Given this list of marker genes Angpt2, Serpini1, F2, Lgals4, Col4a5, Ctsa, Prl3d1 (NCBI Gene Id 18775), Muc5b, Ccl12, Serpinb9c, Serpina10, Adam8, Pgf, Sema3d, Tinag (NCBI Gene Id 26944), Zp1, Fgf7, Sdc1, Adamtsl3, Stfa1, Ccl4, Sbspon, Tnfsf4, Egfl6, S100a1, Wnt9b, Clec12a, Ambn, Serpinb9b, Prl8a1, Ovgp1, Fgl2, Masp1, Fgf23, C1qa, Muc17, Cst11, Creld2, Ngf, Hpse2, Lman1l, Loxl1, Ism1, Cdcp2, Clec2l, Il36b, Fgb, Muc1, Gdf7, Serpina1a (serine (or cysteine) peptidase inhibitor, clade A, member 1A), Fgf4, Clec3a, Nell2, Tnfsf18, Ntn3, Sdc2, Serping1, Ncan, Cst8, Serpinb3b, Gm13285, Clec4b2, Col3a1, Ifna15 (NCBI Gene Id 242517), Fgf20, Serpinb5, Col6a4, Igfbp7, Reg3a, Adamts12, Fgf2, S100a11, Fbn1, S100b, Pdgfd, Lama5, Fgf11, Adam1a, Spock2, Pdgfb, Angpt4, Col13a1, Col17a1, Il1rn, Thbs2, Adam12, Col4a1, Adam6b, Ccl3, Acan, Cbln3, Elfn2, Prss3l, Serpinb9, Pik3ip1, Cst3, Col6a6, Ccl1, Cxcl12, Hyal3, Npnt, Wnt8b, Gdf11, Fndc7, Col23a1, Fndc1, Adam33, Comp, Adam32, Lgi1, AW551984, Astl, Lgals3 (NCBI Gene Id 16854), Cxcl15, Pcsk5, Gdf15, Ifna9, Mmp23, Il18, Fstl3, Pxdn, Lgals1 (NCBI Gene Id 16852), C1qtnf12, Fn1, Adam23, Fgf10, Tnfsfm13, S100z, Nrg4, Serpinb2, Anxa9, Clec5a, Adamtsl5, Gpc1, Sftpc, Tnn, Bmp8b, Lama3, Pappa, Impg1, Serpinb6d, Egln3, Gdf10, Sema6a, C1qtnf1, Agrn (NCBI Gene Id 381587), Serpina3c, Il36rn, Reg2, Ifng, Bglap3, Serpinb9f, Chad, Adamts6, Masp2, Tnfsf9, Lefty2, Prl2b1, Sema5a, Wnt11, Serpinb6c (NCBI Gene Id 97849), Vwa3a, Csta2, Serpina6, Shh, Ints6l (NCBI Gene Id 75165), Lta, Csf3, S100a7a, Serpinb12, Adam1b, Mmp14, Nid1, Fam20c, Fgf22, Fgf21, Cxcl10, Serpinb7, Bmper, Fgf12, Col9a3, Lum, Serpinb9e, Fgf6, F7, Adam30, Gdf1, Il2, Vwce, Ifna12, C1qtnf3, Epo, Nell1, Nyx, Adamts3, Emcn, Plau, Pamr1, Muc15, Mfap5 (microfibrillar associated protein 5), Mfap1b, Gm5849, Ctsk, Serpina1d, Papln, Col5a3, S100g, Cripto, Ogn, Col5a2, Il7, Plxnb2, Timp3, Clec12b, Prl7d1, Egfem1, Ibsp, Gdf6, Vwde, Wnt2b, Mfap3, Ccl8, Prss12, Anxa11, Mmrn1, Tgm1, Fcnb, Prl8a2, Lgals7, Megf11, Cts3, Slit2, Sema3f, Col8a2, Hrnr, 1810010H24Rik, Mmp9, Cpn2, P4htm, Thpo, Clec4d, S100a2, Fmod, Mmp10, Tnfsf12, Mepe, Emilin3, Emid1, Fgf17, Cd209a, S100a4, Adamts20, Chrd, Sparcl1, Cxcl9, Egfl8, Adam18, Adamts2, Ccn6, Cspg4, Artn, Tll1, Tnfsf11, Hmcn1, Sema6d, Mmp17, Il17c, Serpina7, Plat (plasminogen activator, tissue), Ccn2, Egf, Cfc1, Prl2a1, Fgfbp1, Sema5b, Bmp4, P4ha3, Pappa2, Stfa2, F12, Itih1, Clec2i, Mmp7, Timp4, Lgals9, Wnt3, Cxcl2, Mfap2, Gdnf, Rspo3, Il36a, Col9a2, Itih5, Cxcl1, Dmbt1 (deleted in malignant brain tumors 1), Prl8a8, Il11, Angptl2, BC051665, Ccl20, Dmp1, Tnfsf10, Htra1, Csf1, Agt, Cd209d, Cilp2, Fgf8, Mmp20, Reln, Cela3a, Mfap4, Serpine3, Ccl24, Adam19, Il10, Adam4, Lrg1, Ntn4, Ctsf, Sema4c, Serpina1b, Gpc4, Slpi, Mmp27, Wnt5a, Serpinb11, Plg, Prss1 (NCBI Gene Id 22071), Serpina1e, Prl8a6, S100a9, Spon1, Fbln5, Megf6, Lamc1, Fgf5, Prl7a1, Itln1, Col20a1, Gldn, Prl7c1, Lman1 (NCBI Gene Id 70361), Serpina3k, Serpina5, Ints14, Colec10, Il12b, Igfbp4, Fgf18, Lgals12, Clec4a2, Mep1a, Plxna4, Clec3b, Il16, Sema4f, Nrg2, Ccl27a, Ccn4, Col6a1 (collagen, type VI, alpha 1), Ifna1, Angptl1, Rspo2, Ihh, S100a16, Col25a1, Ccl7, Gpc2, Clec2j, Il4, C1qtnf2, Rspo1, Ctf2, Hapln1, Parm1, Vwc2l, Sftpd, Serpinb1a, Tgfb3, Vwa7 (NCBI Gene Id 27762), Serpinb13, Sema6c, Colq, Clec2e, Lama4, Plxna1, Bsph1, Epgn, Bmp1, Ifna4, Kcp, Lama2, Sema7a, Ctsd, Muc21, Adamts8 (ADAM metallopeptidase with thrombospondin type 1 motif 8), Bmp7, Col12a1, Sema4g, Eda, Cd109, Ecm1, S100a3, Igfbp2 (insulin-like growth factor binding protein 2), Reg1, Ctsl, Col6a5, Try5, Srgn, Gdf2, Tnfsf14, Igsf10, Xcl1, Mbl2, Zpld1, Il23a, Rptn, Adamts16, Igfbp3, Igfbpl1 (NCBI Gene Id 75426), Adamts10, Oit3, Tecta, Ifna13, Angptl4, Fbln1, Fbln7, Ctsq, Ifna2, Anxa4 (annexin A4), Cilp, Cts7, Cstdc3, Col4a2, Prss1l, Ccn5, Gm13283, Timp1, Pdgfa, Fstl1, Spock3, Matn3, Crnn, Prl3d2, Inha, Abi3bp, AI182371, Lamc2, Il1b, Thbs4, Nrg3, Mmp1a, Adamts5, Hyal4, Wnt7b, Loxl3, Prl2c2, Gm4787, Flg, Spon2, Col18a1, Nid2, Il17d, Slit3, Sema6b, Serpinb9d, Lamb1, Adipoq, Ctsc, Ifnb1, Wif1, Adam2, Tgm2, Stfa3, Plod2, Edil3, P4ha1, Fgf15, Tnf, Serpina11, Wnt10a, Hspg2, Rspo4, Gm13277, S100a8, Gm13288, Ccl19, Gpc5, Mmp8, Ebi3 (Epstein-Barr virus induced gene 3), Tnc, Crim1, Mdk, Otog, Mug2, Reg3d, Pcsk6, Ctsg, Vit, Podn, Adamtsl4, Ctsz, Ecm2, Col1a1, Lgi4, C1qtnf9, Wnt3a, Zp3r, Il15, Wnt4, Crispld1, F13b, Prg3, Hyal5, Fbln2, Serpina3a, Muc6, Serpina3g, Tnfsf13, Muc19, Lefty1, P4ha2, Sfrp1, Ppbp, Col2a1, S100a6, Gm5409, Tsku, Ccbe1 (NCBI Gene Id 71072), Insl5, Lgi2, Ccl26, C1qtnf5, Gdf5, Vwc2, Tgfa, Adam26a, Ptn (pleiotrophin), Fgl1, Adam5, Ltbp3, Clec10a, Hpse, Tchh, Il1a, Fga, Anxa10, Plxna2, C1ql2, Cst6 (NCBI Gene Id 98169), Inhbb, Cbln2, Mmp13, Wnt1, Slamf6, Zpld2, Col6a2, Bsph2, Clec4e, Il20 (NCBI Gene Id 58181), Podnl1, Igf1 (insulin-like growth factor 1), Brinp2, Lep, Cx3cl1, Clec2h, Clec1a, Mmp19, Igf2, Fgf9, Wnt2, Col11a2, Sned1, Sema4b, C1ql4, Col7a1 (NCBI Gene Id 12836), Itih4, Srpx, Gm13271, Prl3c1, Serpinc1, Gdf3, Pspn, Adam26b, Zp3, Kera, Cd209b, Fras1, P3h1, Itih3, Prl8a9, Col27a1, Crhbp, Lamb2, Adam21, Reg4, Sfrp2, Lif, Igfbp1, Col26a1, Sdc3, Serpine2 (serine (or cysteine) peptidase inhibitor, clade E, member 2), Bmp2, Serpina3f, Col19a1, Adam7, Pzp, Csf2, Bmp8a, Prl, Colec12, Wnt7a, Tmprss15, Sdc4, Ccl6, Mstn (NCBI Gene Id 17700), Vegfa, Sparc, Kazald1, Chrdl2, Ntn5, Il17b, Plod3, Hyal6, Ctsw, Ntn1, Colec11, Megf9, Tgm3, Hhip, Vwa5a, Sema3g (NCBI Gene Id 218877), Ctf1, Vegfd, Nrg1, Sema3a, Gm13287, Bmp6, Vtn, Adamtsl2, Sema3b, Anxa8, Il1f10, Clec2d, Sfrp4, Serpinb1b, Ambp, Grem1, Scube3, Serpinb8, Ndnf, Ccl9, Crlf1, Prol1, Ogfod1, Ctse, Clec4g, Matn2, Wnt10b (wingless-type MMTV integration site family, member 10B), Lamb3, Cela1, Adamts13, Mep1b (NCBI Gene Id 17288), Clec7a, Adamts19, Fgf14, Il5, Clec4a4, Pdgfc, Mfap1a, Anxa13, Adamts1, Clec4b1, Ntf3, Serpinb10, Amelx, Pf4, Cxcl13, Pcolce2, Lgals8 (lectin, galactose binding, soluble 8), Vwa2, Lox, Frem2, Adam25 (ADAM metallopeptidase domain 25), Gdf9, Emilin2, Cntf, Itih2, Sfta2 (NCBI Gene Id 433102), Clec14a, Col6a3, Bmp10, Il17a (interleukin 17A), Adam6a (a disintegrin and metallopeptidase domain 6A), Mmp12, Col4a6, Loxl2, Ifna16, Prl7a2, Slit1, Srpx2, Prss3, Ins1, Muc20, A2ml1, Spock1, Amh, Mucl1, Pcolce, Ccl11, Vwf, Col22a1, Hapln2, Serpinb6b, Ctso, Vwa5b1, Ltbp1, Ntng1, Plod1, Prl2c5, Hmcn2, Cdcp3, Wfikkn1, Cbln4, Il17f, Megf8, Sema4d, Matn1, Cbln1, F9, Igfals, Dpt, Aebp1, Htra4, Ccl21a, Serpinb3d, Ifnab, Htra3, Bmp3, Prl2c3, Scube2, Hpx, Megf10 (NCBI Gene Id 70417), Col10a1, Fndc8, Reg3g, Lgals2, Mst1, Kng2, Cst7, Serpinb3a, C1ql1, Try4, Col15a1, Serpinb3c, Cstl1, Anxa2, Tnfsf8, Bmp5, Inhba, Prss2, Cela2a, Adamts4, Ins2, Adam11, Clec9a, Serpinh1, Serpina3b (NCBI Gene Id 271047), S100a5, C1ql3, Egflam, Angpt1, Ccl22, Ky, Gas6, Nodal, Ntng2, Dspp, Muc2, Col24a1, Adam29, Gm5347, Smoc2, Mmp3, Clec11a, Tchhl1, Clec4a3, Vcan, P3h2, Lgalsl, Tgm5, S100a14, Ifna5, Angptl3, Tnfsf15, Eln, Cts8, Insl6, Clec4a1, Adamtsl1, C1qtnf4, Epyc, F13a1, Sulf1, Sema4a, Fgf3, Cstdc1, Wnt9a, Ereg, Vegfc, Esm1, A2m, Mgp, Serpina12, Tgm4, Angptl7, Crispld2, Kitl, Sema3e, Cst13 (NCBI Gene Id 69294), Prl2c1, S100a10, Adam15, Sfrp5, Clec4f, Ctsj, Cxcl11, Col5a1, Ifna6, Ccn1, Serpina1f, Clec4n, Cstb, Grifin, Cts6, Ifne, Vwa3b, Il22, Gm13276, Tectb, Cstdc2, Serpinf2, Muc4, Mmp16, Ctsll3, Cela3b, Mbl1, Gpc6, Spinkl, Adam22, Adam3, Cst5, Fam20b, Clec18a, Il3, Adam20, Fam20a, Omd, Sulf2, Creld1, F10, Col14a1, Il9, Bcan, Il24, Adam9, Tinagl1, Plxna3, Gm13278, Mmrn2, Hyal2, Reg3b, Hapln4, Prl4a1, Cxcl14, Mmp11, Ifna7, Timp2, Dhh (desert hedgehog), Stfa2l1, S100a13, Thsd4, Gh, Fgf13, Ltbp2, Ctss, Wnt8a, Elane, Ctsm, Vegfb, Serpina9, Gm13289, Insl3, Hyal1, Wnt5b, Efemp2, Adam39, Fst, Bgn, Kng1, Sema3c, Prl3b1, Ctsb, Col11a1, Ifnz, Chadl, Anxa6, Egln2, Ifna11, Frem1, Sftpa1, Tpbpa, Cst9, Ltb, C1qb, Tgfb1, Efemp1, Zp2, Anxa7, Chrdl1, Thbs1, Prl5a1, Osm, Tnxb, Smoc1, Tnr, Serpina3m, Serpinb9g, Egln1, Fbn2, Btc, Adam24, Il36g, Emilin1 (NCBI Gene Id 78939), Ifnk, Mmp21 (matrix metallopeptidase 21), Nrtn, Otol1, Fasl, Crlf3, Tnfaip6, Cspg5, Prg4, Mmp24, Tgfb2, Sftpb, Adamts14 (NCBI Gene Id 631313), Prg2, Fgfbp3, Plxdc1, Il25, Flg2, Lgi3, Adamts18, C1qc, Loxl4, Svep1, Sspo, Elfn1, Adamts9, Nepn, Adamts17, Spp1, Frem3, Wfikkn2 (WAP, follistatin/kazal, immunoglobulin, kunitz and netrin domain containing 2), Mmp2, Hbegf, St14, Tgm7, Hcfc1, Brinp3, Fgg, Col9a1, Csta1, Plxnd1, Scube1, Mmp28, Col4a4, Prl7b1, Wnt16, Areg, Serpina3n, Ccl5, C1qtnf7, Serpine1, Tgm6, Ctsr, Cstdc6, Cthrc1, Inhbc, Adam17, Plxnb3, Tnfsf13b, Ngly1, Serpini2, Serpinb6a, Hgfac, Ism2, Bdnf, Ccl17, Prl6a1, Cxcl3, Tll2, Adam34, Clec1b, Egfl7 (NCBI Gene Id 353156), Col4a3, Ccl27al, Ctsh, Tspear, P3h3, Ccl25, Wnt6, Postn, Coch, Il13, Anxa5, Serpinb1c, Ifna14, Fcna, Inhbe, Mfge8, Plxnb1, Mmp1b, Bglap2, Serpind1, Col16a1, Gm13279, Thbs3, Adam10, Clec2g, Gm13290, Otogl, Col1a2, Tpbpb, Muc5ac, Lamc3, Vwa1, Tgfbi, Ccl2, Optc, Il19, Igfbp6, Ltbp4, Prl3a1, Dcn, Habp2, Csta3, Col28a1, Col8a1, C1qtnf6, Adamts15, Tpo (thyroid peroxidase), Ccl21b, Ccn3, Try10, Il6, Spam1, Il12a, Il34, Ccl28, Cxcl5, Ogfod2, Angptl6, Adamts7, Serpinf1, Igfbp5, Impg2, Adam28, Flt3l, Gm13272, Bmp15, Vwa5b2, Serpina1c, Clcf1, Aspn, Gm13275, Anxa3, Hapln3, Prelp, Fgf16, Cstdc5, Prl3d3, Plxdc2, Gpc3, Frzb, Muc16, Adamdec1, Plxnc1, Hgf, Cst12, Lama1, Matn4, Mmp15, Erfe, Cstdc4, Muc13, Ntf5, Fgf1, Hrg, Anxa1, Hcfc2, Mmp25, here is a description of the gene set: One hallmark of ECM proteins is their domain-based structure. Exploiting this characteristic, we established a list of diagnostic InterPro domains commonly found in ECM proteins. We know that some of the domains used to select positively for ECM proteins are also found in transmembrane receptors and proteins involved in cell adhesion (growth factor receptors, integrins, etc) that do not belong to the ECM. These families of proteins also display a subset of specific domains and transmembrane domains incompatible with definition as studied in species Mus musculus from publication Naba A, Clauser KR, Hoersch S, Liu H, Carr SA, Hynes RO (PMID 22159717) Mouse Gene Set: NABA_MATRISOME Ensemble of genes encoding extracellular matrix and extrcellular matrix-associated proteins